The following is a description of a gene set: One hallmark of ECM proteins is their domain-based structure. Exploiting this characteristic, we established a list of diagnostic InterPro domains commonly found in ECM proteins. We know that some of the domains used to select positively for ECM proteins are also found in transmembrane receptors and proteins involved in cell adhesion (growth factor receptors, integrins, etc) that do not belong to the ECM. These families of proteins also display a subset of specific domains and transmembrane domains incompatible with definition as “extracellular matrix” proteins. Therefore, a second step comprised a negative selection using another set of domains and a transmembrane domain prediction. Manual curation of the matrisome lists also allowed us to add a very few known ECM proteins that do not contain any known domains. Protein-centric predictions were then converted to gene-centric lists. Finally, knowledge-based annotation of these gene lists allowed us to define subcategories within the core matrisome; namely, ECM glycoproteins, collagens, and proteoglycans. We also defined separate lists of domains commonly found in 1) ECM-affiliated proteins (proteins that share either some architectural similarities with ECM proteins or that are known to be associated with ECM proteins; 2) ECM regulators: ECM-remodeling enzymes, crosslinkers, proteases, regulators etc.; 3) secreted factors, many of which are known to bind to ECM and others that may. As for the core matrisome list, we also defined lists of domains that excluded mis-assigned proteins from these categories. Using similar bioinformatic pipelines as for the core matrisome, we defined three categories of “matrisome-associated” proteins: ECM-affiliated proteins, ECM regulators, and secreted factors. Human Gene Set: NABA_SECRETED_FACTORS from publication Naba A, Clauser KR, Hoersch S, Liu H, Carr SA, Hynes RO (PMID 22159717) studied in species Homo sapiens Genes encoding secreted soluble factors, and this is the list of marker genes: FGF22, HGFAC, WNT16, BMP7, CFC1, BMP8B, IL36G, WNT7B, IFNA21, NRG1 (neuregulin 1), AMH, CLCF1, ANGPTL1, IFNA17, CBLN3, XCL2, VEGFB, CRLF3, GDF2, S100A16, CCL14, ARTN, CSH1, IL24, ISM1, WIF1, HBEGF, NRG2, IL10, IFNA14, IFNA4, HCFC2, TNFSF13B, CSH2, TNFSF13, BRINP3, ANGPTL6, FGFBP1, FGFBP3, INHBE, HGF, IFNB1, EBI3, NRG4, IL26, TNFSF14, FLG2, S100A8, S100A2, FASLG, WNT3A, ANGPT4, WNT7A, CCL4, CCL27, ANGPTL7 (NCBI Gene Id 149217), CBLN4, IFNA6, CXCL14 (NCBI Gene Id 9547), CCL5, CHRDL1, VWC2, TNFSF12, IL17C, CXCL9 (C-X-C motif chemokine ligand 9), IL23A, S100A13, NRG3, TNFSF11, CCL11, FGF13 (NCBI Gene Id 730528), FLG, NGF, CXCL11, WNT9A, IGF1, IL1B, SCUBE1, IFNG, IFNW1, BMP5, WFIKKN1, ISM2, CCL20, CRLF1, FGF23, CCL4L2, IFNA1, IL25, PSPN, VEGFA, MDK, IFNA8, C1QTNF9B, CXCL12, S100A6, BRINP2, VWC2L, CCL7, IL1F10, TCHH, IL18, IFNA7, EPGN, CCL16, GDF11, CCL26, INS (insulin), WNT10A, FGF8, MST1, SHH, CCBE1, S100A7L2, CHRD, GDF7 (NCBI Gene Id 8873), WNT8A, EGFL6, MST1L, FGF5, CCL8, ANGPTL3, WNT2, CBLN1, EPO, HRNR, BDNF, FGF10 (NCBI Gene Id 2255), IFNA16, FGF17, S100B, TGFB1, FGF6, EDA, CXCL6, GDF1, MEGF11, WNT2B, CCL15, IHH, WNT3, INSL6, IL19, WNT11, CFC1B, S100A11, CXCL10, IL20, FRZB, FGF16, CXCL13, FGF11 (NCBI Gene Id 2256), MSTN, FGF7, MEGF9, IL34, NTF3, CCL23, GDF10, CCL28, EGFL8, FLT3LG (NCBI Gene Id 2323), CRIPTO, IL17D, TGFA, IL6, PIK3IP1, IL1A, S100Z, CCL2, IL9, NODAL, FGF20, LTA, EGF (epidermal growth factor), HCFC1, ANGPTL5, MEGF10, FGF19, GDF9, IFNA2, TNFSF10, IL7, IL17B, PPBP, PDGFC, ANGPT1, FGF2, S100A1, IGF2, CTF1, S100A5, FGF1, WNT10B, RPTN, PDGFA, FSTL3, KITLG, LEFTY2, ZFP91, S100A7, XCL1, FSTL1, IL16, CXCL3, FGF4, IL2, INS-IGF2, S100P, S100A4, WNT4 (Wnt family member 4), ANGPTL4, WNT1, INHBB, WNT8B, INHBA, EGFL7, EREG, CCL19, WNT5A, GDF6, ANGPT2, CXCL1, CBLN2, CCL3L3 (NCBI Gene Id 730422), S100A12, IL12B, INHA, S100A9, SFRP1, CXCL2, CCL22, IL4, ANGPTL2, INHBC, IL3, CSHL1, DHH, PF4, IL15, FGF9, S100G, CRNN, S100A3, TGFB3, BMP2, MEGF6, LTB, BTC, BMP4, IL36RN, IL36A, LEP, BMP6, TNFSF18, INSL3, IL17A, CCL1, IFNE, GH1, TPO, SFRP4, IL11, PRL (NCBI Gene Id 5617), GDF3, GDF5, TNFSF4, CSF1, IL17F, CCL17, WNT5B, S100A14 (NCBI Gene Id 57402), FGF18, GDF15, FGF21 (fibroblast growth factor 21), INSL5, PGF, LIF (NCBI Gene Id 3976), NTF4 (neurotrophin 4), CCL24, IL12A, SCUBE2, TNF, BMP8A, BMP15, PDGFD, IL13, VEGFD, CX3CL1, VEGFC (vascular endothelial growth factor C), CXCL5, IL5, CHRDL2, CCL18, CRHBP, FGF3, IFNA13, FGF14, IFNK, WNT9B, IFNA5, CNTF, FST, IFNA10, TCHHL1, TNFSF9, IL36B, OSM, IL22, PTN, CSF3, AREG (amphiregulin), CXCL8, BMP3, FGF12, THPO, S100A7A, TGFB2, BMP10, CCL13, MEGF8, SFRP5, CCL21, SFRP2, S100A10, WNT6, PDGFB, HHIP, CSF2, WFIKKN2, IL37, CCL3, CCL25, GDNF, NRTN, FGFBP2, IL1RN, LEFTY1, TNFSF15, TNFSF8, PF4V1, SCUBE3, GH2